The following is a description of a gene set: ERBB2 Activates PTK6 Signaling species: Homo sapiens Human Gene Set: REACTOME_ERBB2_ACTIVATES_PTK6_SIGNALING, and this is the list of marker genes: NRG2, PTK6, EGF, ERBB2, NRG1, NRG3, BTC, NRG4, ERBB3, HBEGF, ERBB4, EGFR, EREG